The following is a description of a gene set: Binding to a double-stranded DNA region containing an insertion or a deletion. species: Mus musculus Mouse Gene Set: GOMF_DNA_INSERTION_OR_DELETION_BINDING, and this is the list of marker genes: Msh2, Msh6, Msh3, Pms2, Pcna